The following is a description of a gene set: Human Gene Set: GSE15930_STIM_VS_STIM_AND_IL12_72H_CD8_T_CELL_DN Genes down-regulated in comparison of unstimulated CD8 T cells at 72 h versus CD8 T cells at 72 h after stimulation with IL12. Differentiation of naive CD8 T cells into cytotoxic effector cells requires three distinct signals- antigen (signal 1), costimulation -B7-1 (signal 2) and cytokine, either interleukin-12 or interferon-a/b (signal 3). Interaction of naive CD8 T cells with antigen and B7-1 programs cell division and proliferation whereas the presence of cytokines- IL-12 or IFNa/b promote survival, differentiation and memory establishment. In the absence of signal 3, the cells interacting with antigen/B7-1 undergo tolerance induction. The objective of this study was to elucidate the mechanisms how the provision of signal 3 promotes differentiation and averts tolerance induction in CD8 T cells. Trichostatin A is a pharmacological agent that inhibits histone deacetylase activity, hence regulating chromatin structure and gene expression and differentiation in many cell types. Gene signature profiles of IL-12, IFNa/b and trichostatin A stimulated cells were compared to elucidate the molecular mechanisms of gene regulation. Oligonucleotide microarray analysis is carried out to determine the extent and molecular nature of the CD8 T cell differentiation program induced by IL-12 or IFNa/b in concert with antigen and B7-1 signal. species: Homo sapiens from publication Agarwal P, Raghavan A, Nandiwada SL, Curtsinger JM, Bohjanen PR, Mueller DL, Mescher MF (PMID 19592655), and this is the list of marker genes: SRPK1, PEMT, P2RX6, NAB1, RNASE3, SMAP1, NQO1, REXO5, PTPN2, MC1R, SWAP70, RRAGA, PTPN23, SLC38A4, PPIE, SEPTIN2, F8, GABARAPL1, GZMM, SCARB2, MC5R, HAND2, GPR37, SLC44A4, NTN1, EMC4, INMT, IFNB1, RNF181, PIP4K2C, GATA1, NKAIN1 (sodium/potassium transporting ATPase interacting 1, NCBI Gene Id 79570), LCT, SIX5, TCEA1 (transcription elongation factor A1), FAM151A, DVL2, FOLR2, FGD1, FCRLA, RAB5A, MYCBP, SLC25A3, IER3, KRTDAP, SFTPC, HPD, POU3F3, GNPNAT1, UTP3, MORC4, RFK, TIRAP, HSPG2, IL10RA, GJB2, LGI4, ANKZF1, RNF34, ZNF274, POLR3A, TSPAN5, TAGLN2, PTGS1, YWHAB, KCNE1, NCK2, H1-4, OPRD1, NT5DC3, ZSCAN26, PLG, PKHD1, RASA4, GRIA3, RAX, MSI1, ODF1, NR0B2, KLHL21, SLC25A4, IGF1, MYH14, SAA1, IL4, SNX2, GCH1, SYT7, TUBA8, THUMPD1, TFEB, HAX1, TENM1, KTN1, HTR2C, NRCAM, LRBA, SHF, NFU1, FBXO15, PRR15, PGAM2, LRP6, PPIH, VAPA, FLT3, SEMA6C, RGS4, SLC22A5, RAD23A, HSPA5, PON1, MRPL38, SIGLEC1, REEP6, ZNF23, LAMA5, LAMA4, IGFBPL1, SIRT2, MOGAT2, EIF3B, KRT6A, RARS1, MYL6B, IL9, SENP6, MATR3, GFRA1, PENK, VEGFA, SNX21, LTBP3 (latent transforming growth factor beta binding protein 3), WWP2, EOMES, ZDHHC9, NAA80, GNA14, GSPT2, THAP7 (THAP domain containing 7), G6PC2, ZNF444, PRAF2, KDELR3, MEOX1, EFNA5, ELAVL4, GTF2H4, HPN, IL1RAP, NUDT5, MRPL45, TBC1D24, SMARCB1, OR6A2, SNRNP25, REG3G, WNT10B, NPM3, PIP4K2A, PRMT1, PBX3, NACC2, GJA1, TSFM, UBE2A, MYT1, NHSL2, G0S2, SCN1A, GPN3, ELP3, SELENOK, TIMM8A, IRAG1, RPS6KA4, PHLDA2, SCX, PPP6C, HOXC5, KIF3B, SAA4, IRS2, EFNA3, PKP1, IL5, NLRX1, LITAF, IFIT3, TMT1A, IBSP, MSRB1, IL1R1, SCN10A (sodium voltage-gated channel alpha subunit 10), SH3BGR, SLC35A2, PCDH7, FKBP10, GAA, FKBP5 (FKBP prolyl isomerase 5)